The following is a description of a gene set: Human Gene Set: GSE29949_CD8_NEG_DC_SPLEEN_VS_DC_BRAIN_UP species: Homo sapiens from publication Anandasabapathy N, Victora GD, Meredith M, Feder R, Dong B, Kluger C, Yao K, Dustin ML, Nussenzweig MC, Steinman RM, Liu K (PMID 21788405) To understand the functional relationship between brain dendritic cells (brain DCs) and other myeloid cells, we compared the gene expression profile of m/chDCs to that of bone marrow monocytes, brain microglia and classical spleen CD8+ and CD8- DCs. In order to obtain enough brain DCs for mRNA extraction, we expanded brain DCs with in vivo Flt3L treatment before purification. Genes up-regulated in dendritic cells: spleen CD8- versus brain., and this is the list of marker genes: DENND3, ITGA9, TSPAN1, ZNF500, EPS8, KCNK1, NPAS3, FOXD1, ADRA1B (adrenoceptor alpha 1B), KRTAP5-9, NOS1AP, SLC12A4, ASTN2, CENPF (NCBI Gene Id 51468, centromere protein F), PPIE, POLR2F, DHRS3, CAVIN1, KCNJ5, SLC28A2, PLP1, RGS4, KCNJ2, MAST1, AGT (NCBI Gene Id 183), TNN, SLC18A1, CDK6, TGDS, IRS4, WDR77, GPR20, GPER1, TCP10L3, PKLR, SOAT2 (NCBI Gene Id 8435), SLC30A3, ADAMTSL2, RAG1, CXCR3, IRF6, GUCA1B, OR10H3, MCF2, EXT1, ANXA9, IQCE, DSC3, CCT6B, SORT1, SCNN1A, SHROOM2, GZMH, NOVA1, PLCB1, DDN, RLBP1 (retinaldehyde binding protein 1), MAPKBP1, ADAM22, MLH1, OVOL3, HOXD13, WNT11, RNASE2, CXCR1, PART1, KCNJ8, YJU2, SYN1, PCNX1 (NCBI Gene Id 23690), NTN3, SAMD14, IGSF9B, CDK20, EXOSC9, H4C13 (H4 clustered histone 13), CYP1A1, ARSD, KIF5A, GATAD1, IFI30, OASL (NCBI Gene Id 8638), SPA17, KCTD2, SLC33A1, GRM1, SMG6, NUDCD3, MTNR1B (NCBI Gene Id 4544), GRIN1, LAIR1, B3GALT4, ORC1, ZNF20, BRINP3, MPZL2, NR5A1, DSCR4, COL4A3, IAPP, SGCG, PTPRD, MAN2A2, DEPDC5, ETV2, PTPN3, PPP1R10, TGOLN2, HCN4, KRT33A (keratin 33A), SLC6A1, RFNG, REG1CP, ABCC2, SCHIP1 (schwannomin interacting protein 1), CYP4B1, IGSF1, ST3GAL2 (ST3 beta-galactoside alpha-2,3-sialyltransferase 2), L1CAM, KSR1, SCGB1D2, RBMXL2 (NCBI Gene Id 27288), DNAH9, NHLH1, SMG7-AS1 (NCBI Gene Id 284649), REST, PSEN2, WDR1, APOE, MYOM1, MMP19, GNB2, COL4A5, TMEM262, ABCD2, BCKDK, CCRL2, ADORA1, ARHGEF16, SULT4A1, HOXC11, MYH11, EFNA4 (NCBI Gene Id 1945), SCN7A, UTF1, NID2, CRP, GNAT1, NRL, CTSG (cathepsin G), DEFB1, EML2, UPK1A, RGS6, ZBTB40, MYCNOS, LLGL2, CCN5, EIF3A (eukaryotic translation initiation factor 3 subunit A), SZT2, CA3, BRCA2, DOC2B, S100B, GTPBP10, SHOX2, EHMT2, ADRB2, TRIM15, PAFAH2, REEP2, MAP2, SOX9, ZIC1, CCN2, PLCB2, ICOSLG, MMP14, THRA, LEFTY2, VSTM4, SLC4A4, MTERF1, EIF4A3, GABRD, SAPCD1, TUBB4B, ST3GAL1, CALML3, KRT32, BRINP2, HOXA4, ADCYAP1